Given this list of marker genes Med23, Il27ra, Ccr2, Ripk3, Cd99l2, Fadd, here is a description of the gene set: Any process that modulates the frequency, rate or extent of T cell extravasation. studied in species Mus musculus Mouse Gene Set: GOBP_REGULATION_OF_T_CELL_EXTRAVASATION